Given this list of marker genes FOXO1, MAP2K1, CHRM2, NMU, MIR200C, TRDN, BMP10, GHSR, IGF1, TNNT3 (NCBI Gene Id 8044), PRKAG3, FKBP1B, MIR145, ATP2B4, CACNB2, PRKACA, MTPN, NR4A3, P2RX4, MSTN, EDN1, RHOA (NCBI Gene Id 387), MIR19B1, SPHK1, FGF13, MLIP, NOS3, MIR25, TNNC2, PDE4D, TMEM38B (NCBI Gene Id 55151), TBXA2R, ZC3H12A, TNNT1, ENO1, MIR199B, CHRNB4, IRAG1, ABCC8, MIR34C, DSG2, ATP1A2, ADRB2, KCNB2, TACR3, ANK2, GSTO1, ARRB1, DOCK5, EDN2, UCN, HDAC4, PPP3CA, CACNB1, ADORA2B, OXT, MYBPH (NCBI Gene Id 4608), CLIC2, CACNA1C, TIFAB (NCBI Gene Id 497189), SCN10A, MIR143, ADCY10, MYL9, SRI, PRKCA, TOMM70, BIN1, CACNG1, TMEM38A, MIR17HG, ERRFI1, MIR214, NEUROG1, MIR133A1, CHGA, SMAD7, SLC9A1, ACTN3, BECN1, PARP2, MYOCD, SUMO1, DMD, JPH3, HRC, SETD3, MYOG, SMAD4, JPH4, HSP90AA1, TNNI3, KCNQ1, TACR1, MIR21, MIR34B, SLN, KCNA1, NKX2-5, ARHGAP42 (Rho GTPase activating protein 42), JPH1, ATP1A1, KIT, ABAT, EDN3, ATP2A1, FBXO32, TNFRSF1B, CASQ1, CAV3, CALM3, ROCK1, P2RX1, CNN1, JPH2, STRIT1, RGS2, CHRM3, PROK2, MIR153-1, SMAD3, ADGRD1, RYR2, DLG1, APLNR, KCNJ2, JUP, NPY2R, NOL3, TPM1, CTDP1, MIR19A, STUB1, TRIM63, ADA, GSTM2, ZDHHC21, DMPK, CHRNA3, STC1, PPARA, GLRX3, PDE4B, MIR17, HAND2, CERS1, GJA5, DAPK3, PAK1, MIR30E, ATP1B1, TNNT2, SLC8A1, DSP, ADRA1A, C12orf57, NOTCH1, PKP2, MYBPC3, DAG1, MYL3, MEF2A, SCN4A, TRPC3, MIR199A1, CAMK2G, CAV1, CALM1, IL6ST, PI16, SCN5A, ANXA6, CASQ2, ASPH, NOS1, FOXO3, GPER1, SLC8A3, AKAP6, ADRA1B, MYL2, KBTBD13, MIR1-1, ARRB2, KLF4, ADRA2A (NCBI Gene Id 92480), MYH7, FOXP1, TACR2, SOD1, RGS4, MIR20A, CACNA1S, ATP2A2, PRKD1, ORMDL3, GSK3A, MIR499A, MIR208A (NCBI Gene Id 406990), MYH7B, PRKG1, LMNA, SRF (NCBI Gene Id 6722), GATA5, MIR208B, MYL5, ACE2, GATA4, F2R, PPP1R12B, IGFBP5, NMUR2, DCANP1, ADRA2C, LMCD1, CTTN, ATP2B1, EHD3, CAMK2D, PLN, SPX (spexin hormone), CTNNA3, RANGRF, TNNI3K, MYLK2 (myosin light chain kinase 2), GTF2IRD1, ROCK2, DSC2, AKAP9, ACACB, G6PD, DOCK4, TNNC1, PIK3CG, TWF1, PARP1, GRK2, GHRL, MIR448, ADRA2B, RNF207, CALM2, CAMK2B, NPPA, ADORA1, REM1, HCN4, FKBP1A, ITGA2, NPNT, YY1, AGT, PDE9A, TRPM4, GUCY1A1, MYMK (NCBI Gene Id 389827), SELENON, TNNI1, CALCA, PPARG, TRPV4, TNFRSF1A, here is a description of the gene set: Human Gene Set: GOBP_REGULATION_OF_MUSCLE_SYSTEM_PROCESS studied in species Homo sapiens Any process that modulates the frequency, rate or extent of a muscle system process, a multicellular organismal process carried out by any of the organs or tissues in a muscle system.